Given this list of marker genes CAMKMT, NMT2, GRK7, GUCY2D, RHO, GNAT1, PCP2, GRK4, SAG (NCBI Gene Id 6295), GUCY2F, GRK1, AIPL1, NMT1, here is a description of the gene set: Human Gene Set: GOBP_G_PROTEIN_COUPLED_OPSIN_SIGNALING_PATHWAY A G protein-coupled receptor signaling pathway that starts with an opsin being activated by a photon, and ending with the light signal being trasmitted through the synapses. The signal can be transmitted via different Galpha subunits types: Go, Gs, Gq, and Gt. studied in species Homo sapiens